The following is a description of a gene set: Sodium:potassium-exchanging ATPases are tetrameric proteins, consisting of two large alpha subunits and two smaller beta subunits. The alpha subunits bear the active site and penetrate the membrane, while the beta subunits carry oligosaccharide groups and face the cell exterior. Human Gene Set: GOCC_SODIUM_POTASSIUM_EXCHANGING_ATPASE_COMPLEX studied in species Homo sapiens, and this is the list of marker genes: ATP1A2, ATP1A3, FXYD4, ATP1A4, ATP1B4, ATP4B, ATP1A1, ATP1B2, ATP1B3, FXYD2, FXYD1, ATP1B1